Given this list of marker genes Rps27a, Rbbp4 (NCBI Gene Id 19646), Trp73, Rbbp7, Wrn, Rfc3, Taf15, Map2k6, Ep300, Rad1, Ppp1r13l, Prkag1, Trp53, Tpx2, Mapkapk5, Brca1, Pip4k2c, Rictor, Daxx, Mta2, Taf8, Ing2, Phf20, Ehmt1, Mapk14, Taf7l (NCBI Gene Id 74469), Kat5, Aurkb, Ccng1, Dyrk2, Top3a, Blm, Taf5, Taf4b, Ccna1, Nuak1, Pou4f2, Taf13, Tbp, Ubb, Cdk1, Supt16, Mre11a, Rpa1, Zfp385a, Brpf1, Taf9b, Mbd3, Sgk1, Taf1, Taf11, Rad9a, Dna2, Nbn, Chek2 (checkpoint kinase 2), Prkag3, Csnk2b, Mapk11, Hus1, Taf6, Taf10, Taf12, Bard1, Pip4p1, Trp63, Brpf3, Taf7, Ppp1r13b, Prmt5, Rbbp8 (retinoblastoma binding protein 8, endonuclease), Ppp2r1b, Pdpk1, Banp, Cdk5, here is a description of the gene set: Reactome Pathway: Regulation of TP53 Activity part of: Transcriptional Regulation by TP53 electronically inferred by orthology from the curated human pathway This event has been computationally inferred from an event that has been demonstrated in another species.<p>The inference is based on the homology mapping from PANTHER. Briefly, reactions for which all involved PhysicalEntities (in input, output and catalyst) have a mapped orthologue/paralogue (for complexes at least 75% of components must have a mapping) are inferred to the other species. studied in species Mus musculus